Given this list of marker genes OXT, GNAQ, PRKAA1, GNRH1, AKR1C2, HMGCS2, PRKCE, CCL19, AKT1, TNC, GNAI1, CCR7, EDN1, SFRP1, P2RY6, AKAP8, ANKRD13C, PTGER2, TNFSF4, PTGDR, PTGER1, PTGER4, CCL21, AKR1C3, PTGDR2, ACACA, AANAT, ADCY6, PPP1R9B, TGFBR3, PTGFR, GNAS, PRKAA2, SCN11A, GNB1 (NCBI Gene Id 87729), YY1, P2RY4, GNG2, here is a description of the gene set: species: Homo sapiens Human Gene Set: GOBP_RESPONSE_TO_PROSTAGLANDIN Any process that results in a change in state or activity of a cell or an organism (in terms of movement, secretion, enzyme production, gene expression, etc.) as a result of a prostagladin stimulus.